The following is a description of a gene set: Human Gene Set: HARALAMBIEVA_PBMC_FLUARIX_AGE_50_74YO_CORR_WITH_28D_MEM_B_CELL_RESPONSE_AT_0DY_POSITIVE Genes positively correlated with memory B cell response at 28d in peripheral blood mononuclear cell in seniors(50-74) after exposure to Fluarix, time point 0D BACKGROUND: Studies suggest that the recall-based humoral immune responses to influenza A/H1N1 originates from activated memory B cells. The aim of this study was to identify baseline, early and late blood transcriptional signatures (in peripheral blood mononuclear cells/PBMCs) associated with memory B cell response following influenza vaccination. METHODS: We used pre- and post-vaccination mRNA-Seq transcriptional profiling on samples from 159 subjects (50-74years old) following receipt of seasonal trivalent influenza vaccine containing the A/California/7/2009/H1N1-like virus, and penalized regression modeling to identify associations with influenza A/H1N1-specific memory B cell ELISPOT response after vaccination. RESULTS: Genesets and genes (p-value range 7.92E(-08) to 0.00018, q-value range 0.00019-0.039) demonstrating significant associations (of gene expression levels) with memory B cell response suggest the importance of metabolic (cholesterol and lipid metabolism-related), cell migration/adhesion, MAP kinase, NF-kB cell signaling (chemokine/cytokine signaling) and transcriptional regulation gene signatures in the development of memory B cell response after influenza vaccination. CONCLUSION: Through an unbiased transcriptome-wide profiling approach, our study identified signatures of memory B cell response following influenza vaccination, highlighting the underappreciated role of metabolic changes (among the other immune function-related events) in the regulation of influenza vaccine-induced immune memory. from publication Haralambieva IH, Ovsyannikova IG, Kennedy RB, Zimmermann MT, Grill DE, Oberg AL, Poland GA (PMID 27317456) studied in species Homo sapiens, and this is the list of marker genes: PDZD11, AKAP12, CERS4, IL32, MRPL48, UQCR10, HDHD3, ZFAND2B, KLRB1, FAHD2B, IGSF22, CSTF3, KMT5B, HCN2, IPO11, BRWD1, ST6GALNAC6, CWF19L2, PEX16, KATNAL1, KRBOX5, AIRE, IQCH, AP5Z1, PDCD10, PSMB8, POLR3A, ATP5MK, TRPV2, PRR5, KRT10-AS1, GLG1, LIN54, NEFL, NDFIP2, CDKN2B-AS1, OSBPL3, NDUFC2, COMMD7, SPN, SNORD34, C14orf132, FPGS, MRTO4, PPIA, ATP6V0E2, ADARB1, SELENOW (NCBI Gene Id 6415), NOTCH2NLA, RNF220, RANGRF, CAMTA1, NSUN5, PIGU, TSPOAP1-AS1, CERK, ZCRB1, PBXIP1, THYN1, HMOX2, MMP24, TOMM5, APOBEC3H, OPTN, CSMD3, SERGEF, KLRG1, GNL1, ZMYM5 (NCBI Gene Id 9205), TMEM222, ELAVL1, CDADC1 (NCBI Gene Id 81602), VAPB, CD99, PI16, RAB25, MIF-AS1, APTX, DCAF8, CAAP1, LYPLA2, NEDD8, RPS27A, ASB1, CERS5, RBIS, PLCD1, GTPBP8, ARMH3, CD2BP2, CXCR6, ZNF701, CACNB1, ERG28, DGUOK, UBE2L3 (ubiquitin conjugating enzyme E2 L3), AFG2A, ZNF763, ZNF688, CD3D, UBE2F, GALM, SH2D2A, NIFK-AS1, HRH4, UBAC2-AS1 (NCBI Gene Id 100291967), SMIM27, RPL27A, UBL7-DT, SNORD35A, APOBEC3F, PUM3, RWDD1, UBL5, NAP1L4, ITGB1BP1, ARFRP1, RNF187, MEAK7, LOXL1, MDH1, PSMC5, PTGER2, SIRT5, ACVR2A, PYCR3, MVK, INPP5B, ILRUN, LINC00892, LINC00426, UGP2, HDDC3, CCM2, VRK3, EYA3, TBX19 (NCBI Gene Id 9095), UBE2D2, SELENOH, TRAPPC2, ZGPAT, MLH3, RPL23A, SNORD54, RPL39, PCID2, BRD7, PDAP1, ATPAF1, NEIL2, RPL37, ANAPC7, RINL, ETFB, PAPOLG, BTBD6, UNG, MLH1, NHSL2, TOP6BL, CRYBG2, UQCRQ, DNAJC19, RBMX2, PRR13, ZNHIT6, TTLL1 (TTL family tubulin polyglutamylase complex subunit L1), NDUFB9, SSNA1, DUT, RPS7, ZNF674, PCNX3, COMMD4, TRNAU1AP, LRFN2, ZNF133 (zinc finger protein 133), HCST, COX6C, THOC3, NDUFA9, TEDC2 (NCBI Gene Id 80178), KLHL35, USP31 (ubiquitin specific peptidase 31), SNORD4A, C19orf12, RAB22A, TMEM171, TRIM2, NUDCD3, DLG3, METRN, UQCR11, DOK6, RFC4, TMEM191A, TXNL4A, GOLGA7B, ZNF585A, AGFG2, ARL6IP4, NDUFA2, PARP1, STXBP4, CHN1, IPP, ZNF530, COMTD1, NDUFB2, CD47, SNF8, PHF19, TGDS, PECR, ZDHHC13, ENSA, FXYD1, GTF3C1, CNPY2, THAP3, CCDC65, LCMT1, CDKN2A, CACNB2, RPA3, JAKMIP1, ATP5IF1, MRPL52, SF3B3, MRPS25, FTSJ1, MAVS, FTX, UTS2, SLC25A26, SNHG20, EIF5B, TMEM50B, SH2D1A, BLCAP, PIN4, TLE5, MTLN, LINC01011, SNAP47, TSPAN15, ZNF670, NAALADL1, CLEC2D, COG2, SETD4, RAB29, RNF8, NDUFA4, IMMP1L, NAXE, LIME1, PRSS27, ATP5F1D, SYNJ2BP-COX16, ZC3HC1, RPL32, PCYT2, INSIG2, SMIM29, WDR4, TMEM14A, CARD8, RPA1, AMZ2, ACTR3B, SARS1, FANK1, POLR2F, NFATC3, NENF, JTB, PSMD13 (NCBI Gene Id 5719), PAFAH2, IFITM1, GFER, FAM219B, CHMP4A, RPS6, NAA38, PSME1, POLH, LRTOMT, TRAPPC4, LRRC1, HCFC2, UFD1, TARBP2, RUVBL1, MAPT, MICOS10, CCDC57, LYSMD1, HNRNPA3, KDM5A, CROT (carnitine O-octanoyltransferase), VBP1, AAGAB, EVA1C, MAF, CEP250, ZNF780A, PRR5L, MYL6, MED4, ATG13, C11orf58, SOD1, PHTF2, PPP2R5C, UQCC6, HIKESHI, EBAG9, SNORD38A, TRADD, KIF3A, WDR83OS, RPL14, MADD, ANGPT2, CDRT4, SPEF2, MOB2, TMEM106C, B3GAT3, LOXL1-AS1, ZNF621, FUT2, RECQL5, GUK1, PLAAT4, HOXC4, SERPINI1, OSER1-DT, SAMM50, CD27-AS1, KIFAP3, TTC39C, SLC25A15, STOM, SNRPN, CHMP6, GPI (NCBI Gene Id 2821), MAX, RCN2, BDH2, SERF2, TINF2, SP140, FAT2 (FAT atypical cadherin 2), PGAP3, MFF (mitochondrial fission factor), NSMCE1, SCAMP3, TBC1D24, DHRS13, RPL13A, ZNF780B, GTSE1-DT, PDP2, ARHGEF39, PHKG2, UNC45B, SRPRB, SEMA4F, MBD3, DIAPH1, MEI1, LTBP4, GSDMD, LBHD1 (LBH domain containing 1), MPRIP, CYP20A1, PKNOX1, RANGAP1, IL2RG, LYAR, MUC6, UBA52, AARSD1, PPP1R12B, ATG5, PTPN7, ZNF233, SNRPE, HENMT1, SYTL1, ZNF738, CPNE7, DGKZ, TRIM65, AP2B1, SYNRG, PEF1, PPIE, ITPRIPL1, APOBEC3D, RDH16, ZNF428, MAPK11, ATAD3C, LY75, N6AMT1, C1orf56, RPS29, TEX264, NOP14-AS1, LINC02591, TSPAN5, ASTN2, MBP, SMAD4, MECR, POLR3GL, CIAO2B, SIGIRR, CLIC5, UQCRB, SNRPC, NDUFB11, GLE1, RPS19, SKP1, CCDC85B, RNASEH2C, MMAB, TRAPPC6B, MRPL11, SLC25A12, APOL2, RETREG3, RAI14, YAF2, ALKBH3, RNF167, PRMT2, EEF1D, TADA3, HINT1, MCOLN3, BCL7C, ATAT1, COX14, SLC25A51 (NCBI Gene Id 92014), RPS23, TNNC1, BUB3, STK24, ABCC5, VPS4A, GTF2IRD2B (NCBI Gene Id 389524), TMEM178B, USP46, LAGE3, MAP4, LACTB2-AS1, KPNA1, TMEM161A, FAIM, HSPBP1, USP37, ETV2, HTT, NECAB1 (NCBI Gene Id 64168), BAX, BATF, ATP5MG, MCRIP1, AFAP1-AS1, SLC39A8, FDXR, USP5, PMVK, TNFRSF4, MRPL57, COMMD6, SRI, CACNA1C, MVD, UGGT1, PSMD9, STX8 (NCBI Gene Id 9482), CYTOR, KLHDC4 (kelch domain containing 4), COPS9, PCED1B-AS1, UNC13D (NCBI Gene Id 201294)